Given this list of marker genes ARHGAP26, SPRED2, RRAS2, MAP2K1, BRAF, CBL, RASA2, RIT1, LZTR1, SOS1, NF1, MRAS, SOS2, NRAS, KRAS (KRAS proto-oncogene, GTPase), RAF1, PTPN11, RRAS, here is a description of the gene set: Juvenile myelomonocytic leukemia (JMML) is a lethal myeloproliferative disease of young childhood characterized clinically by overproduction of myelomonocytic cells and by the in vitro phenotype of hematopoietic progenitor hypersensitivity to granulocyte-macrophage colony-stimulating factor. Human Gene Set: HP_JUVENILE_MYELOMONOCYTIC_LEUKEMIA Juvenile myelomonocytic leukemia species: Homo sapiens